Given this list of marker genes H2-D1, Tapbpl, H2-Q6, H2-Q7, Tapbp, Pdia3, H2-Q4, H2-Q2, H2-K1, Calr, H2-Q1, H2-Q10, Tap2, Tap1, B2m, here is a description of the gene set: Mouse Gene Set: GOCC_MHC_CLASS_I_PEPTIDE_LOADING_COMPLEX studied in species Mus musculus A large, multisubunit complex which consists of the MHC class I-beta 2 microglobulin dimer, the transporter associated with antigen presentation (TAP), tapasin (an MHC-encoded membrane protein), the chaperone calreticulin and the thiol oxidoreductase ERp57. Functions in the assembly of peptides with newly synthesized MHC class I molecules.